The following is a description of a gene set: Mouse Gene Set: GOBP_GOLGI_TO_LYSOSOME_TRANSPORT The directed movement of substances from the Golgi to lysosomes. species: Mus musculus, and this is the list of marker genes: Gak, Ap4m1, Rbsn, Ankfy1, Cln3, Ap1g1, Laptm5, Sort1, Ehd3, Ccdc91, Lamp1